The following is a description of a gene set: Mouse Gene Set: MP_DECREASED_METASTATIC_POTENTIAL Mouse genes annotated to decreased metastatic potential (MP:0001273) retrieved from the Mouse Genome Informatics database via MouseMine studied in species Mus musculus from publication Motenko H, Neuhauser SB, O'Keefe M, Richardson JE (PMID 26092688), and this is the list of marker genes: Plau, Pld1, Stab2, Nbeal2, Rhoj, Fbln5, Cxcr2, Bcl11b, Jam3 (junction adhesion molecule 3), Vegfa, Fut7, Stat6, Id1, Cybb, Mgat5, Sell (selectin, lymphocyte), Lyst, Fos, Cd96, Atf3, Tmem219, Hcst, Mmp9, Il1a, Il1b, Ccm2l, Ccr5, Ifngr1, Npr1, Vegfd, Anxa1